The following is a description of a gene set: A process that identifies and degrades defective or aberrant RNAs within the nucleus. studied in species Mus musculus Mouse Gene Set: GOBP_NUCLEAR_RNA_SURVEILLANCE, and this is the list of marker genes: Exosc7, Exosc3 (NCBI Gene Id 66362), Exosc6, Exosc8, Exosc5, Xrn1, Wdr82, Exosc9, Zcchc7, Exosc4, Dxo, Exosc2, Zc3h4, Dis3, Exosc10